Given this list of marker genes BMP6, EPCAM, NOTCH4 (notch receptor 4), TGFB1, NOTCH1, PPM1F, RGCC, PLG, VEGFA, NEXMIF, MAD2L2, here is a description of the gene set: species: Homo sapiens Any process that stops, prevents, or reduces the frequency, rate or extent of cell-cell adhesion mediated by cadherin. Human Gene Set: GOBP_NEGATIVE_REGULATION_OF_CELL_CELL_ADHESION_MEDIATED_BY_CADHERIN